Given this list of marker genes MAGT1, PDGFB, STAT6, IRF4 (interferon regulatory factor 4), BCL10, EIF2AK4, SMO, HLA-DPB1 (major histocompatibility complex, class II, DP beta 1), NCF2, NCF1 (NCBI Gene Id 653844), NF2, PIK3CG, RHBDF2, EWSR1, SUFU, CYBB, GLMN, HLA-B, PIK3CA, LTBP1, SMARCB1, CYBC1, PRKCD, SMARCE1, AGR2, BRD4, TRAF7, BCL2, MALT1, IRF1, FBLN5, NUTM1, HLA-DRB1, P4HA2, BCL6, PORCN (NCBI Gene Id 65017), BAP1, EFEMP2, GNPTAB, PTPN22, RASGRP1, AKT1, DNAJC21, TERT, FOXP1, BIRC3, CYBA, BTNL2, NCF4, SBDS, EFL1, WT1, APOE, NAB2, here is a description of the gene set: studied in species Homo sapiens Abnormality of the thoracic cavity Human Gene Set: HP_ABNORMALITY_OF_THE_THORACIC_CAVITY